Given this list of marker genes Rnf123 (NCBI Gene Id 84585), Phf11b, Tmc8, Xpot, Slc22a3, Tnrc18, Prickle2, Akap6, Gpx4, Parp11, Adra1b, Clca2 (NCBI Gene Id 99677), Banf1, Nlrp10, Rnf220, Gnaq, Dhrs2, Nav3, Trappc2b, Cpne1, Mrgprf (NCBI Gene Id 211577), Polr2m, Tm7sf2, Tor2a, Nat8f7, Ube2i, Ccar1, Bnip2, Fam209, Rac2, S100a6, Myct1, Xpo7, Tra2b, Ran, Cd2ap, Sumo1, Stx1a, Lmna, Nup155, Dpy19l2, Iffo1, Mad2l1bp, Sorl1, E2f5 (NCBI Gene Id 99821), Gapdh, Mlip, Rnf13, Dnase1, Ptges, Ccnd1, Nxt2, Nos1 (NCBI Gene Id 76730), Tmem170, Tmem168, Gata6, Uaca, Maco1, Cdk4, Nup85, Dnajb2, Pom121 (NCBI Gene Id 97245), Dync2i2, Abcf1, Mtmr6, Habp4, Dnajc2, Lypla1, Gsto1, Nlrp6, Eif6, Chmp6, Cuedc2, Ryr2, Ltc4s, Majin, Osbpl3, Sun3, Tmem53, Rnf43, Ankrd17, Mlx, Alox5, Dtx2, Shisa5, Nup35, Nup153, Brip1, Lemd2, Stx1b, Pld6, Lemd3, Pla2g4c, Dmpk, Zbtb1 (zinc finger and BTB domain containing 1), Rif1, Akirin1, Prkg2, Creb3l4, Smox, Gapdh-ps15, Sun2 (Sad1 and UNC84 domain containing 2), Chmp1b, Spdya (speedy/RINGO cell cycle regulator family, member A), Mindy3, Cep131, Rogdi, Gch1, Nrxn1, Erbin, Nup50l (NCBI Gene Id 78482), Spag4, Mx2, Parp16, Klhdc2, Ern1, Ttc12, Anxa4, Wdfy3, Prnp, Cbx3, Nos1ap, Nup214, Thap7, Sephs1, Nup43, Tmem38a, Scai, Rbmx2, Cetn2, Rae1, Bicd2, Igf2r, Myorg, 2210016L21Rik, Agpat3 (1-acylglycerol-3-phosphate O-acyltransferase 3), Hsd11b1, Tpr, Rb1cc1, Cemip, Nxf1, Htatip2 (NCBI Gene Id 54425, HIV-1 Tat interactive protein 2), Pik3c2g, Canx, Retsat, Smad1, Lrrc59, Cenpv, Aaas (achalasia, adrenocortical insufficiency, alacrimia), Rnf180, Zc3hc1, Kcnh1, Tent4a (NCBI Gene Id 210106), Itgb4, Chmp1a, Rap1gap2, Dtl, Vapa, Fzr1, Syne1, Kash5, Tmc6, Chmp3, Nrm, Slc22a18, Il15ra, Ipo5, Mgst3, Lmnb1, Ugt2b1, Spast, Dhcr7 (7-dehydrocholesterol reductase), Mrps23, Ranbp2, Eno1, Senp2, Mns1, Sh3bgrl2, Nsmf, Myo6, P2rx7, Vps4b, Golt1a, Gmcl1, Cask, Dnajb12, Parp8, Hoxa7, Ist1, Des, Zfp354c, Plpp6, Rrp12, Trim27, Cav2, Pcm1, Ei24, Tmem120a, Osbpl6, Prickle1, Mx1, Nudt9, Mfsd10, Vcf2, Tnks2, Rangap1, Ptgs1, Tnks, Nup62, Ipo8, Ghdc, Mgst2, Xpo4, Ednra, Dctn5, Fancl, Itpr3, Sigmar1, Txlng, Taf3, Nemp2, Mrps14, Syne2, Gabrb1, Bche, Psen1, Kpna2, Atraid, Yeats4, Plaat3, Slc30a1, Noc4l, Parp6, Tmem120b (NCBI Gene Id 330189), Phf11a, Tnpo3, Rrm2, Dhx37, Slc29a2, Rab40b, Tamalin, Tyro3, Ngfr, Atr, Chmp4b, Psen2, Phf11d, Plpp7, Sun5, Mad1l1, Nup160, Mta1, Spin1, Dync1h1, Osbpl8, Chmp1b2, Nup210l, Zfp383, Ints1, Pcid2, Ifi27l2b, Brox, Sort1, Chmp2a, Mpl, Nup107, Dnajc1, Lmo7, Gper1 (NCBI Gene Id 76854), Pla2g4a, Kif5b, Tor1aip1, Tmem109, Nxf2, Tor1b, Nup54, Phf8, Tmem33, Rrm1, C9orf72, Ackr2, Tmem176b, Nup58, Bcl2, Pafah1b1, Pcna, Grk5, Fam169a (family with sequence similarity 169, member A), Mapk3, Cse1l, Apoe, Dusp2, Plcb1, Clmn, Phf11, P2rx6, Epc1, Ache, Chmp4c, Cacybp, Ebp, Atp1b4, Zftraf1, Nat8f3, Ednrb, Ugt2b5, Nup50, Nradd, Mtor, Npc1 (NPC intracellular cholesterol transporter 1), Ints2, Ptgs2, Tfdp2, Cnep1r1, Tmx4, Vrk2, Pak5, Inpp4a, Rgs7, Ipo11, Ahctf1, Nup37, Spata46, Slc16a3, Prkcz, Fbxw11, Xpo1, Rbm15, Chmp5, Tmem18, Ptgds, Wtap, Nell1, Tor1a, Casc3, Tmem97, Pgrmc2, Nucb2, Rtel1, Cst3, Gtpbp4, Ifi27l2a, Dctn1, Cdh5, Pum2, Epha3, Lpin1, Nup205, Gapdhrt2, Sirt1, Kpnb1, Agpat5, Dnajb14, Bnip3l, Ugt2b37, Lmntd2, Otulinl, Rtcb, Kpna2rt, Zmpste24, Tug1, Tnmd, Ndel1, Chmp7, Chil3, Oit3, Cptp, Cybb, Hlcs, Brap, Calr (NCBI Gene Id 12317), Narf, Irag2, Osbpl7, Tubb5, Bcl2l1, Tex2, Sun1, Wdr3, Lrpprc, Eif5a, Pom121l2, Sdcbp, Ints5, Clip1, Aqp1, Phf20, Itpr1, Suv39h1, Myof, Lbr, Terb2, Ccnd2, Nutf2-ps1, Egfr, Bnip3l-ps, Unc50, Bok, Sec13, Nemp1, Sts, Alox5ap, Bax, Hax1, Nup42, Lrrk2, Myzap, Anxa11, Kpna4 (karyopherin subunit alpha 4), Ndc1, Bcl2l10, Fam3b, Surf4, Rnf6, Bin1, Eny2, Nup98, Tor3a, Ipo7, Tbc1d20, Ghrhr, Ctdnep1, Plaat1, Aen, Itprip, Tor4a, App, Prr14, Faf1, Trpc7, Gtf3c3, Mad2l1, Tmem43, Smad3, Terb1, Rbm15b, Ranbp17, Nup88, Snca, Arl6ip6, Tmem201, Gchfr, Ggn, Tmem147, Hacd3, Apc, Pak1, Cenpf, Syne4, Bnip1, Ptger4, Emd, Ambp, Clic1, Napepld, Lmnb2, Pcyt1a, Fxr1, Nutf2 (NCBI Gene Id 68051), Lmntd1, Bnip3, Dst, Cdk2, Plrg1, Tmem209, Cd38, Itsn1, Tmpo, Nr4a1, Scrn1, Ptger3, Parp1, Ifi27, Nup133, Smpd4, Ubxn4, Gle1, Phf11c, Nup210, Repin1, Ctnnb1, Kcnj11, Cep128, Stau2, Nxt1, Adra1a, Apeh, Ak9, Klk6, Cetn3, Iigp1, Calr3, Insr, Phlpp1, Hpn, Sult1e1, Senp1, Nup188, Nup62cl, Ugt2b38, Qrich2, Pml, Cmtm3, Srsf1, Mtdh, Seh1l, Gapdhrt, Ranbp1, Cept1, Ipo9, Anxa7, Scgb1a1, Rasa1, Atp5mf, Ddx19b, Nudt1, Syne3, Utp18, Elavl4 (ELAV like RNA binding protein 4), Pola1, Eno1b, Akr7a5, Rtn4, Nup93, Chmp2b, Disp3, Mcm3ap, Vps4a, here is a description of the gene set: species: Mus musculus The double lipid bilayer that encloses the nucleus, separating its contents from the cytoplasm. It consists of an inner and outer nuclear membrane, with an intermembrane space (20-40 nm wide, also called the perinuclear space) between them. The envelope is supported by the nuclear lamina and contains nuclear pore complexes, which regulate molecular transport. Mouse Gene Set: GOCC_NUCLEAR_ENVELOPE